The following is a description of a gene set: Mouse Gene Set: GOBP_AUTONOMIC_NERVOUS_SYSTEM_DEVELOPMENT The process whose specific outcome is the progression of the autonomic nervous system over time, from its formation to the mature structure. The autonomic nervous system is composed of neurons that are not under conscious control, and is comprised of two antagonistic components, the sympathetic and parasympathetic nervous systems. The autonomic nervous system regulates key functions including the activity of the cardiac (heart) muscle, smooth muscles (e.g. of the gut), and glands. species: Mus musculus, and this is the list of marker genes: Gdnf, Pds5a, Slc6a4, Ackr3, Hes1, Phactr4, Tbx1, Hlx (NCBI Gene Id 15284), Phox2b (NCBI Gene Id 245706), Sema3f, Ntf3, Nrp1, Trp63, Vcam1, Adarb1, Gfra3, Insm1, Fzd3, Nav2, Ret, Hand2, Sox8, Phox2a, Ascl1 (NCBI Gene Id 17172), Sema3a, Tlx2, Six1, Sox10, Ednrb, Gata3, Hoxa1, Nrp2, Tfap2b, Plxna3 (plexin A3), Ctnnb1, Tfap2a, Erbb2, Fn1, Plxna4, Ednra, Gbx2, Hes3, Prlh, Egr2, Ntrk1, Sox11, Kif26a, Hoxb2, Sox4, Nf1, Hoxb1 (NCBI Gene Id 15407)